Given this list of marker genes MAP2K2, MAPK8IP1, SPAG9, KSR2, MAPK8IP3, IQGAP1, MAPK8IP2, MAP2K1, KSR1, DUSP19, SH3RF1, AKAP13, here is a description of the gene set: studied in species Homo sapiens Human Gene Set: GOMF_MAP_KINASE_SCAFFOLD_ACTIVITY The binding activity of a molecule that functions as a physical support for the assembly of a multiprotein mitogen-activated protein kinase (MAPK) complex. Binds multiple kinases of the MAPKKK cascade, and also upstream signaling proteins, permitting those molecules to function in a coordinated way. Bringing together multiple enzymes and their substrates enables the signal to be transduced quickly and efficiently.